Given this list of marker genes Fgfr2, Ltk, Ephb1, Ror2, Epha10 (Eph receptor A10), Flt1, Tyro3, Pdgfrb, Kit, Rabgef1, Ddr1, Ret, Ntrk2, Mertk, Ntrk3, Pdgfra, Epha7, Ros1, Epha8, Tie1, Fgfr4, Alk, Epha3, Ddr2, Epha5, Igf1r, Met, Fgfr3, Erbb2, Sh2b3, Flt3, Epha4, Insrr, Axl, Musk, Epha1, Ephb2, Erbb4, Fgfr1, Flt4, Ephb4, Epha2, Egfr, Ephb3, Mcemp1 (mast cell expressed membrane protein 1), Tek, Kdr, Fer, Insr, Csf1r, Ntrk1, Mst1r, Epha6, here is a description of the gene set: studied in species Mus musculus Any process that results in a change in state or activity of a cell or an organism (in terms of movement, secretion, enzyme production, gene expression, etc.) as a result of a stem cell factor (SCF) stimulus. Mouse Gene Set: GOBP_RESPONSE_TO_STEM_CELL_FACTOR